The following is a description of a gene set: species: Mus musculus Multiple myeloma is an incurable plasma cell malignancy for which existing animal models are limited. We have previously shown that the targeted expression of the transgenes c-Myc and Bcl-X(L) in murine plasma cells produces malignancy that displays features of human myeloma, such as localization of tumor cells to the bone marrow and lytic bone lesions. We have isolated and characterized in vitro cultures and adoptive transfers of tumors from Bcl-xl/Myc transgenic mice. Tumors have a plasmablastic morphology and variable expression of CD138, CD45, CD38, and CD19. Spectral karyotyping analysis of metaphase chromosomes from primary tumor cell cultures shows that the Bcl-xl/Myc tumors contain a variety of chromosomal abnormalities, including trisomies, translocations, and deletions. The most frequently aberrant chromosomes are 12 and 16. Three sites for recurring translocations were also identified on chromosomes 4D, 12F, and 16C. Gene expression profiling was used to identify differences in gene expression between tumor cells and normal plasma cells (NPC) and to cluster the tumors into two groups (tumor groups C and D), with distinct gene expression profiles. Four hundred and ninety-five genes were significantly different between both tumor groups and NPCs, whereas genes were uniquely different from NPCs in tumor group C and genes were uniquely different from NPCs in tumor group D. Similar to human myeloma, the cyclin D genes are differentially dysregulated in the mouse tumor groups. These data suggest the Bcl-xl/Myc tumors are similar to a subset of plasmablastic human myelomas and provide insight into the specific genes and pathways underlying the human disease. Human Gene Set: BOYLAN_MULTIPLE_MYELOMA_D_DN Genes down-regulated in group D of tumors arising from overexpression of BCL2L1 and MYC in plasma cells. from publication Boylan KL, Gosse MA, Staggs SE, Janz S, Grindle S, Kansas GS, Van Ness BG (PMID 17483317), and this is the list of marker genes: CTDSPL (CTD small phosphatase like), PBX2, ST3GAL5, PCBP2, KSR1, CASK, WFDC21P, LGALS1, ATP10A, SLC28A2, TIFAB, MAGED1, NFKBIE, SLC37A1, HSD17B11, CTNNA1, EHHADH, PIWIL4, CYBB, EIF2S3, CASP7, TDRD7, UPB1, ARAP2, FLOT2, ARHGAP26, S100A13, PRKRA, DDX3Y, SH3BP1, CASP1, RPGRIP1, ANXA4, IFI27L2, CGAS, ATP11A, CD44, CYTH4, ITGAM, ABHD8, ABTB2, DRAM1, NCF1, PPP1R3E, CHST15, CEROX1, IL7R, EVA1B, SMPD5, NAB2, ARHGAP21, MTCH1, CD52, EZH1, HNRNPLL, TMEM141, CSRP1, PSTPIP2, CCL15, SYNE3, MARCKS, KRT18, BCL3, CCDC88A, IFFO1, CMPK2, S100A1, LIFR, IL2RA, PHKA1, CRYBG1, CSTF2T, GSN, IPCEF1, MAP10, AHNAK, S100A6, PPP1R16B, STK3, DENND1C, LILRA4, PXYLP1